Given this list of marker genes Rae1, Nup93, Ddx20, Nup54, Prmt5, Nup155, Nup85, Nup205, Ndc1, Snrpf, Nup58, Gemin2, Snrpg, Nup210, Smn1, Nup133, Aaas, Snupn, Seh1l, Nup42, Gemin7 (NCBI Gene Id 69731), Gemin5, here is a description of the gene set: species: Mus musculus This event has been computationally inferred from an event that has been demonstrated in another species.<p>The inference is based on the homology mapping from PANTHER. Briefly, reactions for which all involved PhysicalEntities (in input, output and catalyst) have a mapped orthologue/paralogue (for complexes at least 75% of components must have a mapping) are inferred to the other species. part of: Metabolism of RNA Reactome Pathway: Metabolism of non-coding RNA electronically inferred by orthology from the curated human pathway